Given this list of marker genes ELOVL2, FADS1, ELOVL1, SCD5, ELOVL6, ACSL1 (acyl-CoA synthetase long chain family member 1), ACSL3, ACSL4, FASN, ELOVL3 (NCBI Gene Id 83401), ELOVL5, SCD, FADS2, ACOT2, here is a description of the gene set: species: Homo sapiens Human Gene Set: WP_OMEGA9_FATTY_ACID_SYNTHESIS Omega-9 fatty acid synthesis